The following is a description of a gene set: studied in species Mus musculus A component of the cytoskeleton consisting of a homo or heteropolymeric fiber constructed from an indeterminate number of protein subunits. Mouse Gene Set: GOCC_POLYMERIC_CYTOSKELETAL_FIBER, and this is the list of marker genes: Fam110a, Dpysl2, Saxo2, Map1lc3b, Kif26a, Cyld, Grip1, Cenpe, Cd2ap, Kif21a, Cttn, Fam161b, Specc1l, Bfsp2, Spef1 (sperm flagellar 1), Ckap2, Efhb, Rcc2, Chmp7, Tubb4a, Lzts2, Ror2, Tubg2, Cfap53, Casp1, Krt1, Nme7, Svil, Krt74, Vps11, Csnk1d, Gtse1, Kif27, Chmp6, Bex6, Diaph1, Dcx, Tppp3, Prickle4, Carmil1, Cfap107, Gja1, Drd4, Hook3, Krt80, Hook1, Lima1 (LIM domain and actin binding 1), Cdk5rap2, Dync1i1, Ift70a2, Rassf3, Cfap126, Tubal3, Mtcl1, Rsph1, Krt77, Tekt2, Chmp1b, Shroom2, Krt85, Bysl, Tpt1, Myo3a, Mtcl2, Dmd, Shroom4, Cenpj, Tuba3a, Krtap26-1, Kif24, Ccdc181, Wdr90, Haus5, Mefv, Bod1, Clip4, Selenos, Inpp5d, Dynlrb1, Pierce1, Tchp, Krt19, Sctr, Jakmip1, Dnai7, Krt82, Lmntd1, Rac3, Pawr (PRKC, apoptosis, WT1, regulator), Trim54, Dlc1, Radil, Arhgap18, Fkbp4, Cfap52, Krt15, Katnal2, Birc5, Pdlim4, Ttl, Tektip1, Tmem214, Ttll10, Nefm, Ctsh (NCBI Gene Id 13036), Ninl, Krt24, Map6, Krt13, Akap13, Lmnb2, Apc (NCBI Gene Id 11789), Cct4, Matcap1, Kif19a, Dync2h1, Map2k1, Rmdn1, Rac2, Plec, Mid2, Krt222, Mtus2, Rac1, Apc2, Kif2b, Krt12, Dst, Palld, Jup, Spmip5, Numa1, Mns1, Eif3a, Tuba4a, Dcdc2c, Pcp4, Kntc1 (kinetochore associated 1), Ina, Diaph2, Adora2a, Ckap5, Tubd1, Hid1 (NCBI Gene Id 217310), Ackr2, Slc8a1, Apoe, Tsc1, Sync, Tubgcp4, Rgs14, Krt35, Mical1, Zfp804a, Camsap3, Krtap7-1, Rpgrip1l, Cnp, Gper1, Lrrc49, Cct5, Dcxr, Tppp2, Eml4, Fmn1, Twf2, Kif13a, Psrc1, Ndel1, Mta1, Klhl22, Tubb4b, Disc1, Krt31, Efhc2, Zfp207, Kif20b, Map9, Krt9, Togaram2, Tfpt, Krtap3-2, Clip2, Jam3, Kif5c, Cfap68, Tlk2, Dvl1, Spmip9, Kif12, Rtn2, Cfap161, Krtap3-1, Mapre3, Afap1, Chmp4b, Myo1b, Vps18, Klc3, Ift70a1, Whamm, Rassf5, Cep57, Ska2, Clmp, Dctn3, Vim, Incenp, Gabarap, Krt7, Kptn, Kif2c, Slc1a4, Diaph3, Nudc, Arl6, Krt17, Dync1h1, Des, Amot, Dnah12, Slain1, Snph, Rassf1, Kif5a, Dapk3, Tubb2b, Krtap21-1, Myo18b, Krt33b, Krt20, Fam161a, Aif1l, Enkd1, Tcp1, Vps16, Dctn1, Gjb6, Hcls1, Cfap45, Aif1, Vcl, Nav1, Cct8, Ddx6, Nme1, Krt2, Pof1b, Emd, Odf1, Arl3, Map2, Kifc2, Krt4, Kif28, Tektl1, Krtap15-1, Crhbp, Bbln, Gfap, Tpm1, Dusp21, Fyn, Tpgs2, Avil, Macf1, Map10, Dnaja3, Gsn, Cyp2a5, Casp14, Map6d1, Pdlim3, Cct7, Pls3, Kif4, Dnah1, Aspm, Dynlt1b (dynein light chain Tctex-type 1B), Cimip2c, Tpx2, Cep170b, Kcnab2, Kif1b, Htr2a, Ttll6, Lcp1, Tpm4, Keg1, Pacrg, Camsap1, Hck, Ribc2, Krtap9-3, Tuba1c, Ccsap, Kif18a, Tubgcp6, Ttll13, Saxo1, Krt79, Tubb1, Dnm1l, Ribc1, Map4, Tmod1, Spaca9, Myo1a, Krt78, Trip10, Fgf13 (NCBI Gene Id 14168), Katnal1, Prc1, Bicd1, Tpgs1, Cul3, Tubb6, Krtap19-4, Lrpprc (NCBI Gene Id 97785), Dync2li1, Kif21b, Iffo1, Krt32, Camsap2, Mical2, Chmp2b, Cfap276, Invs, Narf, Myh9, Bag2 (NCBI Gene Id 74827), Tekt4, Pcnt, Dynll2, Gm5478, Krt18, Parp4, Kifc1, Lmna, Bfsp1, Mid1, Dmtn, Vmac, Krtap5-1, Pbxip1, Rhoq, Lmod1, Dnah2, Nckap5, Chmp3, Dlg1 (NCBI Gene Id 320792), Nckap5l, Slc8a3, Chmp1a, Krtap6-5, Arhgap4, Abi2, Dusp22, Nes, Iffo2, Opa1, Septin9, Kif22 (kinesin family member 22), Src, Krtap5-5, Hnrnpu, Actg1, Haus2, Haus4, Kif26b, Tppp, Actbl2, Krtap5-2, Calm2, Plk1, Tubgcp5, Cct3, Bex4, Kif3c, Nme2, Gabarapl1, Cotl1, Clip1, Prph, Pycard, Spry2 (sprouty RTK signaling antagonist 2), Tmsb15l, Cald1, Tbcb, Slain2, Marcks, Gas7, Krt73, Krt34, Polb, Upp2, Nde1 (nudE neurodevelopment protein 1), Dbn1, Chmp5, Arfgef2, Dysf, Flna, Chmp4c, Saxo4, Dyrk1a, Misp, Nckap1, Ldb3, Krtap19-5, Spag17, Fign, Kif15, Eml2, Kif17, Ska1, Pde4dip, Flacc1, Gsk3a, Gsk3b, Kif3b, Tmod3, Klc4, Dnah8, Nicn1, Aurkc, Spmip10, Krt84, Acte1, Haus8, Dnal4, Krtap12-1, Reep4, Krt28, Hook2, Krt72, Krt86, Srprb, Serp1, Spag5, Krt6b, Dync1i2, Nek2, Calm3, Cfap20, Kif16b, Sh2b2, Cdk1, Krt16, Actn1, Katnb1, Myo1f, Igbp1, Kif19b, Ptpn20, Klhl21, Cfap77, Kif9, Tmem232, Zw10, Tcp11l1, Clip3, Actb, Cltc, Enkur, Yes1, Krtap5-3, Map7d2, Ppl (periplakin), Dynll1 (NCBI Gene Id 56455), Sirt2, Mapre1, Tubgcp3, Krt26, Spmip11, Sarm1, Shank2, Krt40, Krtap16-1, Kif1c, Lmod2, Myo6, Tubb3, Haus1, Ttll4, Dnm1, Tubgcp2, Nefh, Klc1, Septin2, Reep1, Kif5b, Spag4, Trpv4, Dnah17, Slc8a2, Knstrn, Krt75, Arpc2, Cep57l1, Luzp1, Gng12, Cimap1d, Kif1a, Specc1, Tuba8, Cep295, Krt81, Krtap6-2, Gas2l1, Wipf1, Clasp2, Ttll8, Stim1, Kif6, Evpl, Myo9b (NCBI Gene Id 17925), Myo5a (NCBI Gene Id 57374), Togaram1, Krt90 (keratin 90), Map1lc3a, Mark2, Dbnl, Rab3d, Gm5414, Mapt, Anxa1, Pdlim2, Haus3, Gramd2b, Dnm3, Cfap210, Mid1ip1, Dpp9, Eppk1, Krtap16-3, Fbf1, Kif11, Bcl2l11, Ino80 (INO80 complex subunit), Pak1, Krtap5-4, Krtap14, Krt10, Aurkb, Tbca, Capn6, Stmn1, Fez1, Krt36, Synj2, Tmsb15b2, Twf1, Ttll9, Tuba1a, Myo1c, Stau2, Keap1 (NCBI Gene Id 54157), Spag8 (NCBI Gene Id 433700), Cdk2ap2, Iqgap1, Eml5, Gas2l2, Golga2, Wdr44, Actc1, Rmdn2, Arhgef2, Efcab6, Dynlt2a1, Tuba1b, Cimip2b, Rab11a, Fsd1, Cfap90, Bcas3, Cstpp1, Dpysl3, Saa1, Ccdc57, Tekt5, Mt3, Daxx, Dync1li2, Eml6 (NCBI Gene Id 73111), Krtap19-3, Dnai2, Krt33a (NCBI Gene Id 71888), Cimip2a, Dync1li1, Pierce2, Dcdc2b, Krtap8-1, Tubg1, Ndrg1, Nav3, Fam110c, Dnah5, Abraxas2, Synj1, Kif13b, Tpm3, Spmip8, Cyp2a4, Katna1, Haus6, Krtap4-6, Haus7, Rmdn3, Tek, Krt87, Gas8, Kif20a, Mx2, Txndc2, Gdpd2, Map3k11, Map1a (microtubule-associated protein 1 A), Eml1, Map7, Chmp1b2, Kif2a, Bloc1s6, Kif14, Ttll3, Cfap206, Nin, Arpc3, Pkp2, Nrp1, Ttll11, Baiap2, Tiam1, Tubb2a (tubulin, beta 2A class IIA), Tekt1, Krt76, Dctn2, Efhc1, Espn, Dnai1, Spast, Wdr47, Krtap29-1, Krt25, Krtap19-1, Ptges3, Sybu, Lmnb1, Cct2, Csnk1a1, Krt42, Krt83, Krtap19-9b, Acta1, Actr3, Pdlim5, Kif7, Mapre2, Pdlim1, Fhdc1, Appbp2, Krt5, Kifc3, Krtap3-3, Spag6l, Gas2l3, Krt14, Ska3, Reep2, Bin1, Dynlrb2, Cdk5, Spmip6, Bcl10, Map1b, Whrn, Kif23, Pafah1b1, Kifap3, Fam83h, Fbxw11, Ldlrap1, Map3k1, Cfap95, Mdm1, Sntb2, Odf2, Ttll5, Cldn11, Reep3, Nefl, Cspp1, Kifc5b, Krt27, Dnal1 (NCBI Gene Id 74212), Cep170, Klc2, Krt39, Saa2, Cct6a, Map2k2, Tpm2, Tekt3, Synm, Tube1, Coro1a, Gck, Was, Chmp2a, Shroom3, Eif6, Cobl, Tpm3-rs7, Ezr, Hdac6, Map1s, Coro1b, Aurka, Ak1, Krt6a, Cfap144, Hsph1, Shtn1, Krt71, Lmntd2, Dnm2, Ttll1, Tubb5, Cdk5rap3, Krt23 (NCBI Gene Id 94179), Rnf4 (ring finger protein 4), Cimap1a, Nusap1, Pls1, Calm1, Dsp, Cfap141, Krtap19-2, Eml3, Cep162, Ift70b, Krt8, Atat1, Rusc1, Odf4, Ccdc66, Iqgap2, Hspa8, Kif18b, Clasp1, Akna, Shroom1, Dynlt3, Dnah3, Kif3a, Pdlim7 (NCBI Gene Id 71959), Fmn2, Myo9a, Ttll7, Dcdc2a, Cfap96